Given this list of marker genes TNFRSF12A, KRT14, ACTN1 (actinin alpha 1), CCN1, SERPINF1, CAVIN1, CALD1, LGALS1, S100A2 (S100 calcium binding protein A2), MYC (MYC proto-oncogene, bHLH transcription factor), TIMP1, SPARC, ITGA6, AREG, CAV1, MT1X, ACTA2, TPM2 (tropomyosin 2), KRT15, COL17A1, ITGB1, FHL2, IGFBP7, C1R, VIM, TAGLN, PDLIM1, MYL9, POSTN, KRT17, LAMB3, TGFBI, COL18A1, COL7A1, CRYAB, CCL2, MMP10, IFITM3, DCN, IGFBP2, ITGB4 (integrin subunit beta 4), MT2A, KRT5, DST, PHLDA1, FLNA, MT1E, SFN, CXCL14, LAMC2, here is a description of the gene set: studied in species Homo sapiens Human Gene Set: GAVISH_3CA_METAPROGRAM_EPITHELIAL_EMT_LIKE_1 from publication Gavish A, Tyler M, Greenwald AC, Hoefflin R, Simkin D, Tschernichovsky R, Galili Darnell N, Somech E, Barbolin C, Antman T, Kovarsky D, Barrett T, Gonzalez Castro LN, Halder D, Chanoch-Myers R, Laffy J, Mints M, Wider A, Tal R, Spitzer A, Hara T, Raitses-Gurevich M, Stossel C, Golan T, Tirosh A, Suvà ML, Puram SV, Tirosh I (PMID 37258682) Genes upregulated in subsets of cells of a given type within various tumors In this study, an extensive analysis was conducted to define meta-programs (MPs) capturing intra-tumor heterogeneity across a spectrum of tumor types. The approach utilized non-negative matrix factorization (NMF) to analyze each cell type separately within individual tumor samples. This involved the analysis of malignant cells, macrophages, fibroblasts, endothelial cells, epithelial cells, T-cells, and B-cells. NMF was executed with varying parameter values (K=4, 5, 6, 7, 8, 9), thereby generating 39 programs for each cell type per sample. Each NMF program was summarized by the top genes based on NMF coefficients.\nRobust MPs were then delineated for each cell type using a set of stringent criteria, including recurrence within the same tumor, similarity to programs in other tumors, and non-redundancy within a tumor. Subsequently, these robust NMF programs were clustered (per cell type) based on Jaccard similarity, leading to the identification of MPs associated with each cell type.\nTo enhance the quality of the MPs, a refinement steps were undertaken, involving the removal of MPs suspected of reflecting low-quality data (with an overrepresentation of ribosomal proteins or mitochondrial-encoded genes), single-study inclusion, or similarity to miss-annotated cell types.